Given this list of marker genes Uba52, Hspa1b, Atp5me, Klf2, Ubb, Hspa1a, here is a description of the gene set: Cytokines mediate cell-cell communication in the immune system and represent important therapeutic targets. A myriad of studies have highlighted their central role in immune function, yet we lack a global view of the cellular responses of each immune cell type to each cytokine. To address this gap, the authors created the Immune Dictionary, a compendium of single-cell transcriptomic profiles of more than 17 immune cell types in response to each of 86 cytokines (>1,400 cytokine-cell type combinations) in mouse lymph nodes in vivo. A cytokine-centric view of the dictionary revealed that most cytokines induce highly cell-type-specific responses. For example, the inflammatory cytokine interleukin-1β induces distinct gene programmes in almost every cell type. A cell-type-centric view of the dictionary identified more than 66 cytokine-driven cellular polarization states across immune cell types, including previously uncharacterized states such as an interleukin-18-induced polyfunctional natural killer cell state. studied in species Mus musculus from publication Cui A, Huang T, Li S, Ma A, Pérez JL, Sander C, Keskin DB, Wu CJ, Fraenkel E, Hacohen N (PMID 38057668) Mouse Gene Set: CUI_T_CELL_GD_IL_Y_RESPONSE_DN Genes negatively differentially expressed in cell type: γδ T cell upon treatment with cytokine: IL-Y in mouse lymph nodes in vivo.